Given this list of marker genes Ndel1, Prep, Mme, Proc, Nln, here is a description of the gene set: species: Mus musculus Catalysis of the hydrolysis of a peptide bond in an oligopeptide, i.e. a molecule containing a small number (2 to 20) of amino acid residues connected by peptide bonds. Mouse Gene Set: GOMF_OLIGOPEPTIDASE_ACTIVITY